Given this list of marker genes Ctsg, Col18a1, Prss2, Prss3, Plg (plasminogen), Mmp8, Mmp15, Mmp11, Mmp2, Cma1, Mmp7, Mmp17, Mmp3, Try10, Mmp25, Elane, Mmp10, Timp1, Mmp14, Spock3, Klkb1, Mmp13, here is a description of the gene set: electronically inferred by orthology from the curated human pathway part of: Degradation of the extracellular matrix studied in species Mus musculus This event has been computationally inferred from an event that has been demonstrated in another species.<p>The inference is based on the homology mapping from PANTHER. Briefly, reactions for which all involved PhysicalEntities (in input, output and catalyst) have a mapped orthologue/paralogue (for complexes at least 75% of components must have a mapping) are inferred to the other species. Reactome Pathway: Activation of Matrix Metalloproteinases